Given this list of marker genes CAPZB, MATN1, LBR, COL24A1, IMPG2, SAP30BP, ABTB2, ATP8B1, YWHAE, TMEM86A, UTY, ELOVL7, KDM5B, PARL, PICALM, AEBP2, PRR16, SRP68, SMAD1, PTPN2, GABRB2, BMPR1B, ELMO1, CDV3, ATF7 (activating transcription factor 7), PSEN1, UBXN1, UBE2L3, HOXC5, ZFP69, FADS6, IRF2, SLC22A9, TPT1, FRYL, TMEM230, PAN3, GALNT2, SH2B3, ZBTB10 (zinc finger and BTB domain containing 10), RWDD3, CPSF7, CILK1, PELI1, ALDH6A1, UBLCP1, CAPRIN1, EMX2, TTC17, KIF21A, ISL1, ITGA6, RARB, H2AZ1, MET, CSMD3, ATP6V1A, SNAPIN, VDAC1, FIGNL1, SCN2B, here is a description of the gene set: studied in species Homo sapiens Genes predicted to be targets of miRBase v22 microRNA hsa-miR-6838-3p in miRDB v6.0 with MirTarget v4 prediction scores > 80 (high confidence targets). Human Gene Set: MIR6838_3P from publication Chen Y, Wang X (PMID 31504780)